Given this list of marker genes Mns1, Hcrtr2, Ccpg1, Dnaaf4, Gm27230, Leo1, Tex9, Mlip, A430027C01Rik, A530064N14Rik, Bnip2, Fam83b, Myo5c, Gm27254, Pygo1, Gm17828, Gm34158, Gm21013, Gm19541, Myzap, Gm34005, Gnb5, Gm19427 (NCBI Gene Id 105243453), Mindy2, Nedd4, Nr1h2-ps, Rnf111 (NCBI Gene Id 93836), Gfral, B230323A14Rik (RIKEN cDNA B230323A14 gene), Cgnl1, Mir5626, 4930590H14Rik, Gm7870, Tcf12, Rfx7, Gm22938, Pigbos1, Bmp5, Uba52-ps, Gm47800, Gm19569, Aldh1a2, Gm19531, Onecut1, Foxb1, Ccnb2, Lipc, Tmod3, Gm25163, Gcnt3, Gm10642, Fam81a, Gm19353, Sltm (SAFB-like, transcription modulator), Lysmd2, Pierce2 (piercer of microtubule wall 2), Gm32017, Adam10, Unc13c, Gm16353, Rsl24d1, Gm5746, Gm27188, Gm9719, Gm22315, 2210414F02Rik, Gm32511, Gm18014, Zfp280d, Rab27a, Gm5745, Pigb, Polr2m, Gm7972, Gm27204, 5730403I07Rik, Gm18745, Gm3671, Tmod2, Gm24615, Bcl2l10, Gm7863, Wdr72, Rpl15-ps2, Gm6018, Gm24257, Gm3436, Klhl31, Gm24141, Mapk6, Scg3, Gm22229, Gm18486, Myo5a, 4933433G15Rik, Gm27234, Gm2981, Lrrc1, Gm16551, Gm23057, Gtf2a2, Atosa, Hmgcll1, Gm27211, Aqp9, Khdc3, Prtg, Myo1e, 4930509E16Rik, Gm18015, Gm18821, Arpp19, Tinag, A730062M13Rik, Gm25045, BC065403, Gm5366, here is a description of the gene set: Mouse Gene Set: chr9D species: Mus musculus